The following is a description of a gene set: Genes down-regulated in comparison of IgD+ B cells from peripheral blood versus CD19 pre-germinal center tonsil B cell studied in species Homo sapiens B cells from human tonsil and blood were sorted using flow cytometry. The human samples were processed immediately ex-vivo using markers for known B cell subsets. from publication Longo NS, Lugar PL, Yavuz S, Zhang W, Krijger PH, Russ DE, Jima DD, Dave SS, Grammer AC, Lipsky PE (PMID 19023113) Human Gene Set: GSE12845_IGD_POS_BLOOD_VS_PRE_GC_TONSIL_BCELL_DN, and this is the list of marker genes: DNMT1, LPIN1, RER1, PPIF, NANS, DCTPP1, SPDL1, TRMT5, MKI67 (NCBI Gene Id 4288), SHCBP1, TACC3, HMGA1, LNPEP, TUT4, ASPM, HSPA5, MCTP2, MYB, UBE2C, PTGDS, HMGN2, ATOX1, SEPHS1 (selenophosphate synthetase 1), CTSD (cathepsin D), DHFR, NCAPD2, PTTG1, KIF15, RUVBL1, ENO2, MAD2L1, CBX5, PRRC2C, ROCK1, SF3B4, MME, SRP54, ANP32B, MAP3K8, KANK1, MARCHF6, MTHFD2, NCAPG, DEPDC1, SMC2, KLHL18, SPATS2, SCAF11, NCAPG2, RNASE1, UBR5, SPAG5, MAGED1, CDK4, ANP32E, MAFB, TFDP1, BCAR3, YWHAE, DCP2, TNS3, AIMP2, NREP, PBK, KIF4A, FANCL, GSN, SFPQ, ALDH18A1, RACGAP1, PAQR4, LPXN, TUBG1, SUMO4, ARPC2, PKD2, SNTB2, RASA2 (NCBI Gene Id 5922), FADS3, CDC45, ADCK2, NDC1, LGMN, PDGFD (platelet derived growth factor D), BIRC2, RFWD3, MANF, MFAP1, H2AC17, KIF23, SPC25 (NCBI Gene Id 57405), CDKN3, PHGDH, CALML4, MORF4L2 (mortality factor 4 like 2), IPO9, RAB11FIP1, TRIP13, PLIN3, NME1, VNN2, CCNB1, METAP2, BANF1, AP2S1, BID, RNF103, ZNF331, FAM120A, SMPDL3A, HSPA8, ARMCX3, EZH2, CDC20, CLASP2, HMGB1, WSB1, USP14, XPNPEP1, NCL, FUCA1, SMARCA4, KIF11, MRPL35, ADAMDEC1, ORC1, DUSP2, GRHPR, FOXM1, CD69, EHD4, ODR4, ATP6V1A, DDX21, SLC1A4, MDC1, SLC43A3, CCT5, RARRES1, MCM7, GLRX5, SRSF1, CSK, MELK, CEP43, RFX7, PLA2G7, CAMK1, ITPR3, SH2B3, ADA, CDC6, EDRF1, KIF20A, SAC3D1, CCNB2, HMCES, ESPL1, FEN1, DPP3, CLTA, DTL, MCM10, ZNF160, RBBP8, CASP3, DLGAP5, SKA1, CTNNAL1, AURKB, CENPE, NFATC2IP, SEC14L1, FNDC3B, TUBB2A, H2AX, POLD1, MTF2, PLXNB2, FANCI, FABP5, SEPTIN11, VGLL4, DDIT4, GRB2, TBC1D4, LRRK1, BRCA2, JPT1, RPLP0, RAD51AP1, NT5DC2, HNRNPA2B1, TERF2, RAD54L, LANCL2, TSFM, PPIA, GINS2, PGAM1 (NCBI Gene Id 95038)